Given this list of marker genes LZTS3, TMEM106B, SHANK1, ARHGAP44, RAB17, MAP2, TRPC6, ITSN1, KIDINS220 (NCBI Gene Id 57498), ZNF296, KHDC3L, PAFAH1B1, KLHL1, CDKL3 (cyclin dependent kinase like 3), CFL1, TRAK1, PAK3, CRK, CAPRIN1, APP, C21orf91, SIPA1L1, SLC11A2, BTBD3, NFATC4, ZDHHC15, HDAC6, DCC, CUX2, IL1RAPL1, PREX2, IGF2BP1, ZNF212, IGSF9, ABI1, DVL1, ITGB1, FARP1, MARK1 (microtubule affinity regulating kinase 1), DPYSL5, PTPRS, SCARF1, NUMBL, MAP1S, SHANK3, NEDD4L, CD3E, SLC12A5, CAMK2A (NCBI Gene Id 815), CUX1, EFNA1, MECP2, ARF4, EPHB2, MATN2, SEMA3A, FMR1, KLF7, SULT4A1, KIF1A, NDP, ABITRAM, DAB1, FZD4, TRAPPC4, PRICKLE1, TULP1, DLG5, GPR37, MCF2, NSMF, GSK3B, CDK5R1, PICALM, KIAA0319, PPP1R9B, PTEN, PDLIM5 (PDZ and LIM domain 5), CAPRIN2, VLDLR, RAP2A, CAMK1D, KNDC1, SEMA4D, CDC42, GORASP1, PSEN1, CUL7, MAP6, MAPK8IP2, CAMK2B (NCBI Gene Id 816), EZH2, SRGAP2C, ABI3, HDAC2, ADGRB3, LZTS1, NRP1, LRP4, ATG16L1, MEF2C, LRRK2, RAB21 (NCBI Gene Id 23011), PAK4, NCK2, TANC2, IL2, MAP1A (NCBI Gene Id 4132), TNIK, CELSR2, ARC, SYNGAP1, PQBP1, GPRASP3, SDC2 (NCBI Gene Id 6383), ATP7A (ATPase copper transporting alpha), MEF2A, ZNF365, SLC30A1, ITPKA, CAMSAP2, LPAR1, GIT1, BCL11A, ACTL6B, RAC1, BBS4, EPHB3, DAB2IP, TPBG, PHACTR1, TAOK2, TRAK2, DLG4, EPHA4, NLGN1, SS18L1, CAMK1, DIP2A, NEUROG3, BMP5, SRCIN1, PREX1, EPHB1, IQSEC1, FOXO6, SDK1, FBXW8, NEURL1, CTNND2, CARM1, CPEB3, LLPH, PACSIN1 (NCBI Gene Id 57564), RAPGEF2, CC2D1A, EEF2K, DCDC2, FLRT1, WASL, DGKG, FSTL4, LST1, YWHAH, MAPK6, RTN4IP1, CHRNB2, GHRL, PARP6, MFSD2A, CDK5, ABI2, CTNNA2, NLGN2, GRIN3A, FAT3, COBL, BBS1, SLC25A46, MAPKAPK5, ALK, CHRNA7, TLX2 (NCBI Gene Id 51407), PTN, FEZF2, NR2E1, FYN, SARM1, CDC20, HECW2, SMAD1, ANAPC2, TRPC5, GPX4, SKOR2, ANKRD27, HECW1 (HECT, C2 and WW domain containing E3 ubiquitin protein ligase 1), STK11, PAK2, DTNBP1 (NCBI Gene Id 84062), MAP1B, PPFIA2, STAU2, DISC1, RELN, ELAVL4, APOE, CRKL, PTPRD, OBSL1, CHRNA3, STRN, TBC1D24, WNT7A, BMP7, ARMCX5-GPRASP2, DSCAM, PRKG1, SRGAP2, DBN1, ARF6 (ADP ribosylation factor 6), DHX36, MGARP (NCBI Gene Id 84709), DOCK10, RERE, ARHGAP33, SLITRK5, NEDD4 (NEDD4 E3 ubiquitin protein ligase), HPRT1, PPP3CA, ABL1 (ABL proto-oncogene 1, non-receptor tyrosine kinase), CDKL5, MINK1, ZMYND8, NGEF, LRP8, SEZ6, BAIAP2, BMPR1A, CSMD3, here is a description of the gene set: Human Gene Set: GOBP_DENDRITE_DEVELOPMENT The process whose specific outcome is the progression of the dendrite over time, from its formation to the mature structure. studied in species Homo sapiens